Given this list of marker genes Ezh2, Krt36, Ovol2, Msx2, Macroh2a2, Etv4, Tgfb2, Foxc1, Notch1 (NCBI Gene Id 68125), Rock1, Rock2, Numa1, Krt84, Prkch, Trp63, Extl3 (NCBI Gene Id 78404), Sgpp1, Reg3a, Errfi1, Zfp36, Macroh2a1, Cyp27b1, Abca12, Srsf6, Ncoa3, Grhl1, Med1, Zfp36l1, Cd109, Hoxa7, Vdr, Alox8, Pkp1, Reg3g, Nme2, here is a description of the gene set: studied in species Mus musculus Mouse Gene Set: GOBP_REGULATION_OF_KERATINOCYTE_DIFFERENTIATION Any process that modulates the frequency, rate or extent of keratinocyte differentiation.